The following is a description of a gene set: Human Gene Set: GOBP_REGULATION_OF_PLATELET_DERIVED_GROWTH_FACTOR_RECEPTOR_SIGNALING_PATHWAY studied in species Homo sapiens Any process that modulates the frequency, rate or extent of the platelet-derived growth factor receptor signaling pathway., and this is the list of marker genes: HIP1, LRP1 (NCBI Gene Id 4035), F7, SNCA, SRC, IFT20, PTPRJ, NDRG4, NHERF1, PTGIR, FSHR, APOD, LOX, IL1B, HGS, PHF14, HIP1R, PTPN2, LRIG2, MYOCD, F3, ADIPOQ, MIR296, CBL, IL1R1, CBLB, PTPN12